The following is a description of a gene set: species: Homo sapiens The nucleus of the female germ cell, a reproductive cell in females. Human Gene Set: GOCC_FEMALE_GERM_CELL_NUCLEUS, and this is the list of marker genes: GTF2B, AIRE, TBP, H2BC1, STPG4, MARCKS, KPNA7, HMGN1, DMRT1, TBPL2, H2AC1, SYCP2L, DNMT1, SLC2A1, YAP1, AURKA